Given this list of marker genes TCF12, CCDC141, SOX3, ARNT2, BBS5, HYLS1, DNAI1, TSHZ1, DDX6, SCP2, SUFU, MICAL1, VPS13C, TRIM32, SLC39A14, TACR3, GNRH1, ARL6, EIF4G1, BAP1, FLRT3, LHB, SCAPER, DNAJC13, DUSP6, SPRY4, BBS10, PIK3CA, SCLT1 (NCBI Gene Id 132320), SRA1, VPS35, GNRHR, GIGYF2, SEMA3A, SOX9, ANOS1, ATP7A, MKKS, NHLH2, OTX2, IL17RD (interleukin 17 receptor D), NSMF, PRDM12, HTT, BBIP1, FGFR1, TAC3, LRRK2, ATP13A2, GBA1, FGF8, PINK1, NPHP1, IFT27 (intraflagellar transport 27), CEP19 (NCBI Gene Id 84984), FSHB, AXL, SDCCAG8, IFT172, PLXND1, REV3L, BBS2, SEMA3E, SMARCB1, CEP290, DCC, HTRA2, FEZF1, NDNF (NCBI Gene Id 79625), BBS7, PROKR2, PTCH2, SCN9A, FGFR2, AKT1, FGF17, TERT, SHH, PTCH1, IFT74, KISS1R, LZTFL1, FGFR3, BBS1, SOX10, MKS1, UCHL1, TTC8, PHYH, SMO, SYNJ1, PRKN, WDPCP, LGI1, FGF10, PEX7, ARSL, TRANK1, SMARCE1, CHD7, PARK7, ANK1, SOX2, TRAF7, PROK2, WDR11, KISS1, DMXL2, PDGFB (NCBI Gene Id 5155), NF2, SMCHD1 (NCBI Gene Id 2490), BBS4, HESX1 (HESX homeobox 1, NCBI Gene Id 8820), DNAJC6, ADCY3, KIF7, RELN, SNCA, ATP7B, PODXL, BBS12, CFAP418, PTPN11, SLC2A3, HS6ST1 (heparan sulfate 6-O-sulfotransferase 1), BBS9, MFN2, here is a description of the gene set: species: Homo sapiens Abnormality of the sense of smell Human Gene Set: HP_ABNORMALITY_OF_THE_SENSE_OF_SMELL An anomaly in the ability to perceive and distinguish scents (odors).